Given this list of marker genes BLM, LAMC2, CREBBP, RMRP, CD28, RSPO1, MVK, ING1, MPLKIP (NCBI Gene Id 136647), CASP10, SEMA4A, STK4, KRT16, KRT17, SOX5, TMC6, PDE11A, ERCC4, ECM1, STAT1, DICER1, SASH3, SMARCAD1, MUTYH, LAMB3, MSH2, BMPR1A, TGFBR1, USF3, PIK3CA, SDHD, RPS19, POLD1, SMARCB1, MITF, PSENEN, STK11, TNFRSF4, MBTPS2, PMS1, POLH, OCA2, TINF2 (NCBI Gene Id 26277), PIEZO1, STIM1 (stromal interaction molecule 1), RNF113A, XPC, PTCH1, CDKN1B, CIB1, WRN, TERC, GATA2, PIK3R1, MSH3, TMC8, KIT, TRPV3, SEC23B, APC, SUFU, TNFRSF10B, KLLN, PDCD1, KRT14, FERMT1, ATR, TGFBR2, ANAPC1, COL17A1, POLE, MMP1, SPI1, EPCAM, ATM, SNAI2, PRKAR1A, NOTCH3, FDPS (farnesyl diphosphate synthase), FAS, GJB4, NLRP1, GPR143, NRAS, DOCK8, GNA14, LRRC8A, ATP2A2, KMT2D, PTCH2, SLC17A9, IL7, FOXE1, TNFRSF1B, PMS2, MEN1, SDHC, ERCC5, RNF31, GATA1, ALX3, TERT, KRT6A, TYR, OCRL, MAD1L1, NUTM1, HPGD, KDSR, CARMIL2, TPP2, TSC1, GJC2, BRCA2, IVNS1ABP, PORCN, BAP1, SASH1, KRT5 (keratin 5, NCBI Gene Id 3852), MVD, ERCC2 (ERCC excision repair 2, TFIIH core complex helicase subunit), AAGAB, CHEK2, SDHB, MC1R, NF2, RASA1, FCN3, AARS1, FGFR1, XPA, GJA1 (NCBI Gene Id 7953), KRT6B, SLX4, FASLG, BRD4, DKC1, SLCO2A1, CARS1 (NCBI Gene Id 833), GJB6, DCLRE1C, CD4, IFNG, MLH1, NAF1, ICOSLG, LAMA3, CYLD, FLT4, CDKN2A, GTF2E2, COL14A1, ERCC3, LRP1, ALK, BLNK, KRAS, PDGFRB, HRAS, IGLL1, CXCR4, RHOH, KEAP1, PERP, COL1A1, DDB2, EP300, NF1, TSC2, UROS, COQ6, SPTBN1, CDK4, IKBKG, ANGPT2, CTNNB1, KDM6A, PRDM10, PTEN, IL6, SPRED1, SLC45A2, SLC39A7, STAT4, TARS1, RAF1, PDGFB, SMO, TCF3, RPS20, LMNA, BPTF, CD79A, CTLA4, FLCN, GJB2, LZTR1, WNT10A, TYMS (NCBI Gene Id 7298), IGHM, AKT1, PLCD1, ZEB2, MSH6, FH, AP3D1, CTSC, CD79B, POGLUT1, SMARCE1, GJB3, GNAS, COL7A1, POFUT1, BRAF, RECQL4, GTF2H5, TP53, NTHL1, TRAF7, SEC61A1, here is a description of the gene set: Human Gene Set: HP_NEOPLASM_OF_THE_SKIN A tumor (abnormal growth of tissue) of the skin. studied in species Homo sapiens Neoplasm of the skin